The following is a description of a gene set: Human Gene Set: MORF_ANP32B studied in species Homo sapiens Neighborhood of ANP32B Neighborhood of ANP32B acidic (leucine-rich) nuclear phosphoprotein 32 family, member B in the MORF expression compendium, and this is the list of marker genes: SNRPE (small nuclear ribonucleoprotein polypeptide E), SNRPB, CYC1, RNPS1, HMGB2, AP2M1, PPM1G, UBE2L3, DDX39B (DExD-box helicase 39B), EIF3K, RPS24, CHD4, NONO, GNAS, ERP29, SNRPD2, EEF2, NDUFA1, CLIC1, NAP1L1, GNB2, COX7C, YBX1 (NCBI Gene Id 7806), HADHA, NPM1, HNRNPA3P1, HDAC1, TAF11, CCT2, PSMB1, EIF3M, SDHA, BANF1, HNRNPAB, ANAPC5, HNRNPUL1 (heterogeneous nuclear ribonucleoprotein U like 1), SNX3, UBE2I, ILF3 (NCBI Gene Id 54783), ACP1 (NCBI Gene Id 52), EIF4G2, SLC25A3, EEF1D, AURKB, CSNK2B, KHDRBS1, SART1, SNRPA1, PABPC1, CTCF, PCBP2, RPL36AL, DRG1 (NCBI Gene Id 4733), RPL14, SNRNP200, PPP1CA, SET, SMARCD2, TUFM, RPS6, RAD21, RPS27A, HSP90AB1, CANX, KXD1, TCEA1, RPL6, SF3B2, RPL18 (ribosomal protein L18), SSR2 (signal sequence receptor subunit 2), COPS5, MRPL9, ATP5F1A, FAU, PCLAF, BTF3, ATP5F1C, RPL24, EIF4B, JTB, HSP90AA1, U2AF1, SF3A2, XRCC6, HMGN1, RPLP2, COX7A2L, UQCRH, TAF7, HNRNPC, PSMB4, COPE, HNRNPD, CCNI, NUDT1, CCT7, HSPD1, BUB3, SRP14, SRSF2, GDI2, RACK1, ELOC, SRSF9, LSM7, COX6A1, RPL10A, FUS, LYPLA1, STARD7, UBA2, TRIM28, CTBP1, SOD1, TATDN2, RAN, CBX3, RPL5, H2AZ2, COX5B (NCBI Gene Id 1329), EIF3C, YWHAQ, RAD23A, HNRNPA1, HINT1, SUMO1, RSL1D1, NDUFS3, PSMB7, EIF3E, FBL, H2AZ1, MCM7, HPRT1, ANP32B (acidic nuclear phosphoprotein 32 family member B), DDOST, RPL7, RPL21, PTBP1 (polypyrimidine tract binding protein 1), MACROH2A1, UQCRFS1, FAM168B, SRP9 (NCBI Gene Id 6726), PARK7, ATP5PO, IST1, SNRPA, RBBP4, MTDH, POLE3, PCMT1, URM1, AZIN1, DAZAP2, COMMD4 (NCBI Gene Id 54939), EIF3G, PPP2R1A, YWHAZ, CALM3, DEK, NCL, RPS12, RALY, CNBP, GANAB, IFT25, EIF4H, EIF4A1, NACA (nascent polypeptide associated complex subunit alpha), ATXN10, SKP1, PUF60 (poly(U) binding splicing factor 60), PDAP1, EIF3H, SRSF3, KARS1, COX4I1, NDUFV1, UQCRB, PSMC1, CDC123, SF3A1, PSMD8, RBMX, COX6B1, COPS6, PCNA, PHB2, SUMO3, VDAC2, BCL7B, EEF1G, SUMO2, HDGF, RPL30, DDX49, CLNS1A (chloride nucleotide-sensitive channel 1A), TARDBP